The following is a description of a gene set: Human Gene Set: MEF2_Q6_01 species: Homo sapiens Genes having at least one occurrence of the motif RGCTATWTTTAR in the regions spanning 4 kb centered on their transcription starting sites. This matches the transcription factor binding site V$MEF2_Q6_01 (v7.4 TRANSFAC)., and this is the list of marker genes: CAPN3 (NCBI Gene Id 825), TFB2M, HSPB3, SV2A, TSPEAR, TRDN, ATP1B2, HJV, DPP10, HIPK1, HDAC4, NIPBL, CASQ2, SLC9A5, RFX3, DNAJA4, CLCN1, HIPK3, RIPOR1, KY, PTCHD4, PLAGL2, WBP4, UNC13D, NEDD4, MACO1, EEF1A2, KCNA7, ARHGAP26, SLC8A3, CNTLN, MORC4, TMEM71, LBX1, ZC3H11A, TPM2, STAC, CASK, KLHL40, SMARCA2, RHOB, SOX5, ZFPM2, ARHGEF37, LGALSL, NOG, TMEM127, DLG2, MYO9A, DIRAS1, ARMCX6, ACTC1, ITGA7, BNC2, PRKAA2, WFDC1, LRRC20, PCDH9, NR0B2, GNB4, HS6ST2, MID2, LIF, PI15, WBP1L, CACNA2D3, COL13A1, TBR1, FOXP1, SCUBE3, MYH6, RARA, COLQ, KBTBD8, GRB14, SLC44A1, EPHX4, USP13, TPBG (trophoblast glycoprotein), PRX, PMEPA1, RNF145, SMARCA1, KCNN1, RCOR1 (REST corepressor 1), SLC2A4, PACS1, CNST, HDAC7, FGF12, CTBP2, NLK, SLITRK1 (NCBI Gene Id 114798), RAP2C, ETV1, MYOZ2, DGKI (NCBI Gene Id 9162), PLPP7, MAFA, CPT1B, TPP2, SLC26A6, STRADB, KCNJ9, ANKMY2, SCAI, TP63, ZNF516-DT, BZW2, TNNI3K, LRRC8C, RASGRF1, ZNF385B, GPR27 (G protein-coupled receptor 27), TNNC1, PAK6, CARTPT, HS3ST2, ZFHX3, PPARGC1A, AKR1B1, LRRC2, HS3ST5, COL1A1, ELAVL4, ARL6IP5, TNNT2, TMEM182, DZIP1L, FXR1, SIX1, CIAO1, C10orf71, PTGR3, POFUT1, CAMK1 (NCBI Gene Id 8536), CELA3A, ZFAND5, KPNA3, FGF13, CUX1, GAN, CKMT2, MFGE8, AQP1, PRRC2C, VEZF1, VCPKMT, RASGEF1B, B4GALT1, AMMECR1, FOXP2, ESR1, USP2, H2BC1, CA7, ADAM11, PABPC4, MYL1 (myosin light chain 1), CTNND2, KLB, FITM1, PDGFRA, SLC16A13, SCN3A, CASQ1, CNMD, TRIM33, CDC42EP3, SLC26A9, KLHL41, INPP4A, NDP, CD180 (CD180 molecule), MBNL2, AAK1, ADCY6, TCEA3, MAP2K5, RALY, GRK7, LHFPL1, NEXN-AS1, PPP1R16B, SMPX, PYY2, PPM1B, TYRO3, KTN1, COL8A1, DCTN1, H2AC1, P2RX5 (NCBI Gene Id 5026), MYL2, ANGPT2, GYG1, SLC6A13, DMD, ART5, CNTN1, PPP2R2A, RHOBTB1, GATA4, IAPP, CLDN14, ATXN1, PRMT3, ATP2A3 (NCBI Gene Id 489), MYOG, STAC3, NCAN, KCNQ5, MITF, ART3 (ADP-ribosyltransferase 3 (inactive)), CRTAP, FRMD4A, ALDOA, JAZF1, CKM, JUN, DLL4, TEF, SSPN, SNAP25, JCHAIN, PER1, IL10, ASIC2, INPPL1, GABARAPL2, TRAK2, LRMDA, YJEFN3, TSC22D1, ZNF362 (zinc finger protein 362), EPHA7, TNNC2, RERE, ASPH, H1-6, XIRP1, UBXN10, ADAMTS12, LYN, GPER1, ARHGEF38, GET4, RIMS2, TRHR, FILIP1